Given this list of marker genes Ptrh2, Lclat1, Dnm1l, Sfrp2, Hivep1 (NCBI Gene Id 15271), Styx, Paip2, Atp11a, Osm, Pm20d1 (NCBI Gene Id 98259), Kmt5b, Tax1bp1, 1110004F10Rik (RIKEN cDNA 1110004F10 gene), Erc1, Depp1, Map3k1, Tpk1, Phf3, Serp1, Ermp1, Rbbp4, Timm9, Atad2b, Tmtc2, Fam107a, D1Pas1, Ppp1r2, Mtfr1l, Kynu, Psme3, Klhl2, Cxcl16, Tnrc6a, Pcdh20, Akap6, Pcdh15, Sytl5, Ggnbp2 (NCBI Gene Id 97681), here is a description of the gene set: Genes predicted to be targets of miRBase v22 microRNA mmu_miR_707 in miRDB v6.0 with MirTarget v4 prediction scores > 80 (high confidence targets). Mouse Gene Set: MIR_707 from publication Chen Y, Wang X (PMID 31504780) species: Mus musculus